Given this list of marker genes DNAJC5, STX1A, SAE1, PRNP, PLK2, HSP90AB1, DDX39B, here is a description of the gene set: Binding to a protein or protein complex using energy from ATP hydrolysis. studied in species Homo sapiens Human Gene Set: GOMF_ATP_DEPENDENT_PROTEIN_BINDING